The following is a description of a gene set: species: Mus musculus Mouse Gene Set: CUI_CDC2_BAFF_RESPONSE_UP Genes positively differentially expressed in cell type: cDC2 (conventional dendritic cell type 2) upon treatment with cytokine: BAFF in mouse lymph nodes in vivo. from publication Cui A, Huang T, Li S, Ma A, Pérez JL, Sander C, Keskin DB, Wu CJ, Fraenkel E, Hacohen N (PMID 38057668) Cytokines mediate cell-cell communication in the immune system and represent important therapeutic targets. A myriad of studies have highlighted their central role in immune function, yet we lack a global view of the cellular responses of each immune cell type to each cytokine. To address this gap, the authors created the Immune Dictionary, a compendium of single-cell transcriptomic profiles of more than 17 immune cell types in response to each of 86 cytokines (>1,400 cytokine-cell type combinations) in mouse lymph nodes in vivo. A cytokine-centric view of the dictionary revealed that most cytokines induce highly cell-type-specific responses. For example, the inflammatory cytokine interleukin-1β induces distinct gene programmes in almost every cell type. A cell-type-centric view of the dictionary identified more than 66 cytokine-driven cellular polarization states across immune cell types, including previously uncharacterized states such as an interleukin-18-induced polyfunctional natural killer cell state., and this is the list of marker genes: Ms4a6d, Ly6e, Pla2g7, Lst1, Cebpb (NCBI Gene Id 18031), Vamp8, Ncf4, Clec12a, Ly6i, Nxpe4, Clec4a3, Cyba, Klra2